The following is a description of a gene set: Abnormal immune serum protein physiology Human Gene Set: HP_ABNORMAL_IMMUNE_SERUM_PROTEIN_PHYSIOLOGY studied in species Homo sapiens An abnormality of the concentration or function of circulating immune proteins., and this is the list of marker genes: IL6R, NFKBIA, HLA-B, ADAR, CARD10, CASP10, CBLB, IL2RB, LSM11, UNC13D, ABCB4, NR1H4, PLCG1, RNU7-1, RNASEH2C, MEFV, FAS, HLA-DRB1, IFIH1, SP110, FASLG, POLA1 (DNA polymerase alpha 1, catalytic subunit), HMOX1, PTPN2, RNASEH2B, LYN, IL2RA, STAT4 (signal transducer and activator of transcription 4), ATP8B1, STAT1 (NCBI Gene Id 6772), STX11, IL12RB1, PSMB8, PTPN22, P4HA2, PTPN6, PSMB9, ELF4, FADD, STXBP2, ANKRD55, RNASEH2A, ABCB11, SASH3, CD247 (NCBI Gene Id 919), TREX1 (NCBI Gene Id 82474), PRF1, SAMHD1 (SAM and HD domain containing deoxynucleoside triphosphate triphosphohydrolase 1)